Given this list of marker genes FGFR2, here is a description of the gene set: FGFR2 fusions have been identified in cancers such as lung, breast, thyroid and cholangiocarcinoma. Of all the FGF receptors, FGFR2 shows the broadest range of 3' fusion partners, including BICC1, AHCYL1, CIT, CCDC6, CASP7, AFF3, OFD1 and CCAR2. Many of these fusion partners contain dimerization domains, suggesting that the resulting fusions may demonstrate constitutive ligand-independent activation. part of: FGFR2 mutant receptor activation Reactome Pathway: Signaling by FGFR2 fusions studied in species Homo sapiens